Given this list of marker genes Ptgfr, Kbtbd2, Xpo7, Lrwd1, Shank2, E2f8, Cxxc5, Maea, Son, Stard4, Rab11b, Lrrn3, Ebf1, Zbtb6, Mcc, Nup160, Slc25a36, Ing4, Rmdn2, Akap5, Hcfc1, Slc17a8, Tbx21, Tead1, Jade1, Tab3, Zfp800, Cbx7, Fam81a, Txlng, Rnps1, Dusp10, Lpp, Mfsd4b1, Akap9, Ldah, Synpr, Osbp, Fut9, Dmrta1, Hes1, Adcy1, Ash1l, Osbpl1a, Sost, Tmtc2, Minpp1, Klhl24, Zmym2, Cav1, Zfp937, Zfp638, Ctdspl2, Casz1, Slit2, Slc25a16, Tle1, Amotl1, Rfx3, Tbc1d9, AI597479, Klhl5, Zfp345, Dach2, Jade2, Kcnmb2, Lpgat1, Anp32e, Aasdhppt, Triqk, Zfx, Hmgb2, Shisa2, Ammecr1l, Kcnip4, here is a description of the gene set: Mouse Gene Set: MIR_676_5P Genes predicted to be targets of miRBase v22 microRNA mmu_miR_676_5p in miRDB v6.0 with MirTarget v4 prediction scores > 80 (high confidence targets). from publication Chen Y, Wang X (PMID 31504780) species: Mus musculus